Given this list of marker genes PDE10A, PRKG2, CNGB1, CNGA4, CNGA2, PDE5A, PDE2A, PDE6H, RAPGEF2, CNGA3, CNGA1, PRKG1, PDE6C, CNGB3, PDE11A, PDE6G, here is a description of the gene set: Binding to cGMP, the nucleotide cyclic GMP (guanosine 3',5'-cyclophosphate). studied in species Homo sapiens Human Gene Set: GOMF_CGMP_BINDING